The following is a description of a gene set: from publication Chen Y, Wang X (PMID 31504780) Genes predicted to be targets of miRBase v22 microRNA hsa-miR-6133 in miRDB v6.0 with MirTarget v4 prediction scores > 80 (high confidence targets). Human Gene Set: MIR6133 species: Homo sapiens, and this is the list of marker genes: ELMOD1, SAMD9, TAB1, ARHGAP19, IGF1R, CERS2, YEATS4, LINC03040, SP1, NIPSNAP1, CWC27, TBC1D16, SLC9A8, ATP6V1B2, MVB12B, UBQLN2, VCF2, OSBP, ARL8A (NCBI Gene Id 127829), LASP1, WDTC1, SHF, ADAM19, NME9 (NME/NM23 family member 9), SLC19A3, DCX, ZNF703, SIGLEC1, IGSF8, SHLD1 (NCBI Gene Id 149840), ENAM, IFFO1, SPRY4, KIAA0513, FRMPD3, CANX, PACS1, NABP2, CD34, MICALL1, HYCC2, LRATD2, IL18R1, IL10RA, FAM131C, TTYH3, SHMT2, ZNF583, STUM, C20orf96, NAA50, ZFPL1, ERI3, JADE2, MIP, SIX2, TRIM16L, ETF1, NELFE, GABRG2 (NCBI Gene Id 2566), SORL1, ALKBH1 (NCBI Gene Id 8846), SLC25A24, SYNGAP1, PPP1R12B, NOTCH3, ZNF782, PABPC1L2B, F9, GTF2A1, MMACHC, GJB3, RAB5B (NCBI Gene Id 5869), ADGRF2P, KIF24, FGD1, RPH3A, PSME3, MAPKAPK2, FBXO45, KLC4, MAPRE1, AKAP13, KCNQ4, PABPC1L2A, SHB, SDF2, LPXN, DLX6 (NCBI Gene Id 1750), INTS6, GPATCH8, STING1, S100A16, ALOXE3, GSK3A, MAPK14, WBP2, KLK4 (kallikrein related peptidase 4), ST3GAL1, RBMS3, MSI1, PAICS, ATP1B2, CLSTN3, NEMP2, EIF4EBP1, LDLRAD3, CLTA (clathrin light chain A), SMG6, RASSF3, MYCL, MPIG6B, CREB3L1, PLXNA4, KDELR2, CERS3, TRIM16, NHLH1, BCL11A, UBL4A, NOL4L, LHX2, PARD3B, GATAD2B, ACVR2A, NYNRIN, CASTOR2, SLC2A3, RCOR1, KIF5A, TET3 (NCBI Gene Id 23298), CHRDL1, DNAH8, SPINK14, BPIFB2, KRT75, EYA3, VTI1A, XYLB (NCBI Gene Id 9942), NXF1, BICDL1, PTMS (parathymosin), CDK5R2, CACNG6, IL2RG, SMAD3, ZNF395, STX2, XPR1, CSNK1G1, DUSP26, GEN1, NOVA2, FOXL2NB, KSR2, DNMT3B, DTX4, POU2AF1, CAMKMT, PRR29, ATAT1, RSPO4, RAB11FIP1, GMPPB, TOLLIP, SDK1, BAZ2A, CDK1, FRY, NUDT18, MECP2, AGAP1, ATP13A3, PLA2G2D, KCND1, CENPP, KCNF1 (potassium voltage-gated channel modifier subfamily F member 1), RAD9A, LURAP1, MSH5, FIGNL2, PAK3, IKBKE, TMEM169, CCDC184, SMOC1, DEFB118, SHE, ABHD2, PADI2, NDST1, TUBB, NFIX, LENG8, PIANP, RNF169, SNX33